The following is a description of a gene set: Genes predicted to be targets of miRBase v22 microRNA mmu_miR_204_3p in miRDB v6.0 with MirTarget v4 prediction scores > 80 (high confidence targets). studied in species Mus musculus Mouse Gene Set: MIR_204_3P from publication Chen Y, Wang X (PMID 31504780), and this is the list of marker genes: Trio, Pafah2, Appbp2, Bahd1, Vcl, Hs3st3b1, Atxn1, Pear1, Setdb1, Rbm14, Grm5, Palm, Ptprt, Tnrc6b, Timp3, Tfg, Rab28, Dock5, Slamf7, Clcn4, Adra1a, Cyb5r2, Cramp1, Ndufaf5, Degs2, Cd83, Trp73, Arhgap32, Zfp592, Cnnm1, Myocd, Tmc5, Slc30a10, Adam30, Hacd4 (NCBI Gene Id 66775), Ppm1d, Aifm3, Sash1, Aak1, Fgf9, Inava, Cpeb1, Neurog2, Meox1, Syt5, Ip6k1, Ntng1, Irf2, Nfasc, Sh3bgr, Ppm1h, Metap1, Ets1 (E26 avian leukemia oncogene 1, 5' domain), Crot, Phf2, Prob1, Rora, Pip4k2a, Sirt2, Ccdc93, Shisa7, Ino80d, Inka2, Srrm2, Rtl5, Cwf19l1, Fn1 (fibronectin 1), Chrm1 (NCBI Gene Id 12669), Idh1, Lyn, Ccdc71l, Faxc, Hs3st5, Kcnv2, Xaf1, Dlg3, Atosb, S1pr3, Gpatch8, Prrg3, Gm9, Sulf2, Homer1, Prokr1, Vdr, Ggt7 (NCBI Gene Id 207182), Cers6, Fhip1b, Rad18, Rtbdn, Npas3, Prickle2, Glra1, Wdr72, Atp1b2, Ednra, Cdh3, Cfl2, Spock1, Mtx3, Fam120c, Mrpl3, Zer1, Asb15, Sh3rf3, Cd209e, Ctsc, Foxn2, Kirrel3, Gdap1l1 (ganglioside-induced differentiation-associated protein 1-like 1), Slc5a3, Zdbf2, Aff4, Smim7, Sh2d1b1, 0610030E20Rik, Zbtb20, Vps26c, Vstm4, Lrrc8e, Kcne4, Kpnb1, Slc22a28, Mob3b, Eef1akmt1, Bco1